Given this list of marker genes HDHD3, CAMSAP3, SDCBP2, PAFAH1B3, BAIAP2L1, MAPK9, PLEKHG3, HLCS, ILDR1, IDO1, PRAG1, TMEM158, MAPK13, TFAP2A, BDH1, DENND2D, ASB8, ZSWIM4, CCDC125, IFI35, IFNGR2, C1orf210, RNF130, IBTK, H2BC11, ADAT1, PGAP3, NHLRC3, NHSL3, RASSF7, OPLAH, TIRAP, GLUL, NIPSNAP3A (NCBI Gene Id 93242), GIPC1, RORC, SLC49A3, TMC4, ALDH3B2, ANKRA2, KLF6, FUNDC1, SLC44A4, TMEM9B, ATG2A, ESR1, STAT6, H2AJ, MARVELD3, DCLRE1C, PODXL, ENPP4, CLDN1, ERBB3, SEPSECS, TJP3, ST14, STAP2, SLC5A1, MTA3, CORO2A, LRRC26, RER1, TNF, KRT18, PAK1, BCL2L13, TMEM139, C11orf52, C1orf56, CLDN7, TST, MUC1, NDUFA7, CLDN8, RAB11FIP1, BIK (NCBI Gene Id 638), SGSM3, SMIM1, TSPAN33, FNTB, MBOAT1, SNX10, RWDD3, HCAR2, SLC28A3, RHPN2, DECR2, NCOA2, TMEM62 (transmembrane protein 62), PGAP2, IDE, GRHL1, ICA1, RAB3IP, KIAA0319L, OXLD1, ELAPOR1, SLC35A1, PSMD10, EVPL, PAOX, PPL, VRK3, TRAM1, RAB25, SNX15, LTF, ZNF524, SYTL4, SNX14, TMEM181, SNRNP35 (NCBI Gene Id 11066), P2RX4, TLR3, PPA2, FGF13, ADD3, PRLR, ABCA3, PNPO, ALAD, PXMP2, UNC93B1, PRKCZ, SCYL3, SIL1, DLG3, IQGAP2, CTPS2, CPT2, BCL3, TFCP2L1, NIPSNAP2, GALE, AP3S2, SLC25A35, CIB1, TMEM41A, LYPLAL1, VILL, SUSD4, EDEM2, PTBP3, ATP6V0E2, DHCR7, PPFIBP2, SNORC, SIGIRR, STX8, HAGH, C1GALT1C1, RNASEH2B, KLK11, STAT5A, KLHL5, THUMPD3, TCIRG1, HDAC10, POLB, SIRT5, ZFP3, CDK19, CXCL17, SLC10A7, GRTP1 (NCBI Gene Id 79774), MTUS1, FRK, CLDN3, OSBPL10 (NCBI Gene Id 54907), KRT8, SULF2, PDZK1IP1, MTIF2, SHTN1, ZDHHC12, ALKBH6, DHX58, THNSL2, PIGO, IVD, PRR13, TPCN1, ZFAND2B, C11orf71, ALDH5A1, RPL22, PYROXD2, TMEM125, CMAS, EHHADH, SORL1, TRAPPC6A, SLC5A6, ALDH1A3 (NCBI Gene Id 90476), LARS1, REEP6, SLC37A1, ZNF750, ELL3, NUP37, TBC1D8, ORAI1 (ORAI calcium release-activated calcium modulator 1), CCT6B, NUDT2, SNX8, SNAP29, HDAC11, ANO9, OS9, KRT19, PLPP6, DERA, FBXO6, TK2, LIPH, POMT1, MPI, NHERF1 (NCBI Gene Id 9368), TMEM128, SFXN1, ERLIN2, DHCR24, SH3BP2, CAPG, MVP, DNAJC12, AP1G2, FOXA1, CLDN4, UROS, PPP1R1B, HOMER2, NECTIN4, MYO5B, PSME1, BTC, PXYLP1, ALG8, GATA3, RABGAP1, CEACAM1, CCNG1, EPCAM, SHMT1, ATP6V1E1, GOLM1, SORBS2, TIA1, ACOT13, ARFGEF3, MB, TSG101, TOM1L1, RAB11FIP4, PTPN6, MLPH, GATB, ZNF334, EPB41, SLC35A3, PLPP2, ZDHHC24, TM7SF2, MYO5C, LRBA, TMPRSS2, ELMO3, CGN, GLE1, RALGPS1, TPD52, SLC22A18, SPATA13, ATP1B1, TMEM54 (NCBI Gene Id 113452), HID1, RBM47, ARHGEF16, SLC39A9, TRIM68, CBLC, PSMB8, C5orf22, ABHD11, KYNU, TANGO2, SLC46A3, CRB3, ANXA7, AKAP10, GCA, CD14, HPN, CACFD1, ACOT8, HTATIP2, BARX2, PACSIN3, COBL (cordon-bleu WH2 repeat protein), ABHD17C, CRACR2B, RNF135 (NCBI Gene Id 84282), SLC39A11, RNASEH2A, BOLA1, CGNL1, CDH1, MRPS21, PI4K2B, NGEF, TGM2, CREB3L4, TDRKH, NEU1, DENND11, GRB7, TSPAN17, CHPT1, TUFT1, STARD10, DMBT1, RFX1, SPDEF (NCBI Gene Id 25803), MBOAT2 (membrane bound O-acyltransferase domain containing 2), ACY1, GCC2, PGD, WNK4, ARRDC4, HMGXB4, PTPRF, AP1M2, RAB5B, BATF, MANSC1, WFDC2, GET1, ACAD10, SQOR, SERINC3, ARRDC1, FAAH, LGALS3BP, SSH3, COASY, IFT43, MAP3K1, RMDN3, TMED3, ARMT1, CHCHD5, CA2, FADD, SLC35D2, NAT1, TNFAIP2, RREB1, ELF3, NUDT1, CD24, SIDT1, TPP1, NDUFV3, PCBD2, TLR5 (toll like receptor 5), CASZ1, FAM110A, MIF4GD, PEX11G, MYH14, TMPRSS13, STXBP2, PPM1H, SULT2B1, SYNGR1, NUP210 (NCBI Gene Id 79985), MCCC2, MBTPS2, LSR, TMEM135, DAPP1, DBNDD2, TLCD4, GABRP, FAM221A, HERC4, DHX32, ZSCAN20, RRM2B, GJB2, SLC16A5 (NCBI Gene Id 9121), CMC1, C1orf50, ERBB2, DHRS4, GSTK1, GSTO2, RAD51D, VTCN1, SDSL, AKIP1, WDR31, MRPL9, LYPD3, GOLPH3L, ISG20, VIPR1, SPINT1, KIF1B, ARPC1A, ACOT4, CLCN3, PKN1, DTX3L, RHBDD2 (rhomboid domain containing 2), here is a description of the gene set: INTRODUCTION: Molecular characterization of the normal epithelial cell types that reside in the mammary gland is an important step toward understanding pathways that regulate self-renewal, lineage commitment, and differentiation along the hierarchy. Here we determined the gene expression signatures of four distinct subpopulations isolated from the mouse mammary gland. The epithelial cell signatures were used to interrogate mouse models of mammary tumorigenesis and to compare with their normal human counterpart subsets to identify conserved genes and networks.METHODS: RNA was prepared from freshly sorted mouse mammary cell subpopulations (mammary stem cell (MaSC)-enriched, committed luminal progenitor, mature luminal and stromal cell) and used for gene expression profiling analysis on the Illumina platform. Gene signatures were derived and compared with those previously reported for the analogous normal human mammary cell subpopulations. The mouse and human epithelial subset signatures were then subjected to Ingenuity Pathway Analysis (IPA) to identify conserved pathways.RESULTS: The four mouse mammary cell subpopulations exhibited distinct gene signatures. Comparison of these signatures with the molecular profiles of different mouse models of mammary tumorigenesis revealed that tumors arising in MMTV-Wnt-1 and p53-/- mice were enriched for MaSC-subset genes, whereas the gene profiles of MMTV-Neu and MMTV-PyMT tumors were most concordant with the luminal progenitor cell signature. Comparison of the mouse mammary epithelial cell signatures with their human counterparts revealed substantial conservation of genes, whereas IPA highlighted a number of conserved pathways in the three epithelial subsets.CONCLUSIONS: The conservation of genes and pathways across species further validates the use of the mouse as a model to study mammary gland development and highlights pathways that are likely to govern cell-fate decisions and differentiation. It is noteworthy that many of the conserved genes in the MaSC population have been considered as epithelial-mesenchymal transition (EMT) signature genes. Therefore, the expression of these genes in tumor cells may reflect basal epithelial cell characteristics and not necessarily cells that have undergone an EMT. Comparative analyses of normal mouse epithelial subsets with murine tumor models have implicated distinct cell types in contributing to tumorigenesis in the different models. Genes consistently down-regulated in mammary stem cells both in mouse and human species. species: Mus musculus Human Gene Set: LIM_MAMMARY_STEM_CELL_DN from publication Lim E, Wu D, Pal B, Bouras T, Asselin-Labat ML, Vaillant F, Yagita H, Lindeman GJ, Smyth GK, Visvader JE (PMID 20346151)